Given this list of marker genes ACCS, TM2D2, SEC31A, ZNF609, BAALC-AS1, COPB1, ENSG00000232995, ACIN1, SMURF1, TRIP11, PPP1R37, BRCA2, MRPS11, CNOT8, DDX59, EDEM1, ADIG, ABRAXAS1, LENEP (lens epithelial protein), CDR2-DT, TRABD, DNAJC11, C8G, RANBP9, SRRM5, SCRIB, GLMP, PHF12, SEMA6A, RPS5, IKBIP, LIN37, OTULINL, SLC9A2, RDH13, MIR4727, ALDOC, TFEB, HYI, C4orf46, AVIL, SLC35B2, TRNAU1AP, RNF114, DDX24, PAFAH1B2, PDAP1, RBM34, CRK, FRS3, RGL2, MSMP, NFIC, ASPHD1, DCK, TNFRSF19, ZNF181, GALC, HYI-AS1, ZNF586, EFNA4, MICA, HDDC3, COMT, ZFAND2B, PIGBOS1, METRN, PIGO, RPL36, SLC39A2, NPL, IRF7 (interferon regulatory factor 7), NOL4L, H2AC6, NOL3, PCDH9, VPS11, CUL9, COX7A2, TAOK2, TBC1D10A, SLC39A6, NDUFA6-DT, PRMT5-AS1, H2BC4, ZNF696, PIGV, DEAF1, MBD4, RB1, PARP12, TTC27, TAMM41, NPLOC4, ZNF587, VPS11-DT, OSGEP, ATP2A1, MADD, PRDX5, PPIL2, FPR1, DCAKD, H1-5, ZNF552, XXYLT1, FOXP1, CAPS2, ARPC2, TSFM, TEX38, ATXN7L3, GTPBP4, ZNF875, APEX1, NELFA, ZFTRAF1, TMEM14B-DT, RALGPS2, CPEB3, PYCR1-AS1, BNIP3L, PMF1, SUSD4, VARS2, ATN1, LSM5, RABIF, MRPS18C, IL17RC, GTSE1-DT, TRMT112, LAMTOR3, CNIH4, CISD1 (NCBI Gene Id 55847), RING1, H2AC11, ZNF211, LRIG3, PIGM, RBM28, MRNIP, WDR87, SEPHS1, FBXO4 (F-box protein 4), POP5, PRKACA, RPS6KL1, PHF1, IFT122, KANSL3, THAP3, ZBTB4, RRP7BP, PHLDB1, FAM118B, COX8A, POMGNT2, SAE1, PLS1, TRMT61A, NOLC1, PFDN2, SF3B6, HYPK, KRT15, CENPA, KSR1, WWP1, HCG25, HIVEP1, ANKZF1, FDX2, NDUFAF1 (NCBI Gene Id 51103), SLC25A22, ARFGEF2, MAD1L1, SRRT, FBRS, LNPEP, BMS1P4-AGAP5, FKBP2, IRS3P, GBA1, PSMB4, RTN4RL2, CLP1, RTBDN, CHMP2A, DPM2, ARL2BP, MKKS, SNRNP48, MSTO2P, HAGH, XKR8, TJP3, AIFM1, ALKBH5, HJURP, PSEN1, POM121C, ALKBH3, NECAP1, LBHD1, SEPTIN1, RNASEH2A, SNRNP25, ENTREP3, H3C7, ATG14, MAN1A2, C1QBP, XYLT2, SEPSECS-AS1, SHQ1, COA8, VPS39, ARL6IP6, CYP2D6, ZHX1, AHCTF1, HMBS, RNU6-1, TOR4A, RIN1, FBXL5, STRN4 (NCBI Gene Id 29888), ZNF410, RAB27A, PSMD14, DPH7, AKTIP, CWC25, LSM14B (LSM family member 14B), DCTN3, COQ7-DT, POLD1, MRPL11, LINC01730, ZC3H3, SMC6, ZAR1L, SAMD8, DPY19L2P3, BMS1P4, NME2, PMF1-BGLAP, SMYD3, LTBP4, SNAPC5, TMEM268, TBX6, EFEMP2, RNU6-1251P, SNX19, SIX5, MRPL38, EXT2, ELK1, VPS4A, TES, MRPL21, AKAP8, ATAT1, MLPH, SUMF2, TAF4, SREBF2, DPCD, SUPT20H, QARS1, KMT2D, SUGT1P3 (SUGT1 pseudogene 3), WDR55, CRELD1, CANX, MYL12A, HEXD, MOB4, CTSB, SYT7, IMPDH1, PIGQ, H2BC13, NDUFV3, LRRC46, EML2, WDR73, LINC02939, DAZAP2 (NCBI Gene Id 9802), LRRFIP2, UBR3, ZNF576, GLI1, NECTIN2, SUMF1 (NCBI Gene Id 285362), NAPRT, APAF1, AFF1, ADD1, EVA1B, C8orf33, GTF2A2, INTS12, NOL12, PYGO2, TAF12-DT, PRKCA, TNFRSF10D, ERCC2, KIFBP, CIRBP, PYCARD-AS1, MTHFS, PRKAR2A, MIR9-1HG (NCBI Gene Id 10485), PRR7, SSBP2, MAF1, XRRA1, TALDO1, SUCLA2-AS1, SNTB2, H2BC18, PTOV1-AS1, MTFR2, CSPG5, CHRAC1, MRPL3, SH3GL1, CDC42BPB, SS18L1, LRATD2, TRAPPC14, PPFIA3, ATP2A1-AS1, RRP15, PSMD6, AP2M1, DBNL, GRWD1, DDRGK1, LINC00235, UBE2Z, UBE2C, AP2A2, H2AC8, CD151, NRGN-AS1, CAAP1, GSTZ1, TXNDC16, CWC27, MRPL53, CHD8, PAWR, PPP6C, GMPPB, NSUN7, PLLP, NR2F1-AS1, ACAP2, UCK1, SUZ12P1, TMEM267 (NCBI Gene Id 64417), SCYL3, NDUFC1 (NADH:ubiquinone oxidoreductase subunit C1), JPT2, ERCC5 (NCBI Gene Id 2073), NRGN, KMT5A, RAE1 (NCBI Gene Id 8480), SEMA3A, SPEF1, AMH, B3GNT8, TMEM139-AS1, CDC37L1-DT, ARHGAP44, ZNF8, ZNF587B, ATAD3B, C21orf91 (NCBI Gene Id 89755), UBXN2A, TMEM182 (transmembrane protein 182), LRRC7, RER1, WDHD1, MAPK1IP1L, DGAT1, MEMO1, INO80E (INO80 complex subunit E), ENSG00000260136, SDHAP4, RNA5S12, ACTR6, GTF3C5, KLHDC9, WDR5B-DT, CCAR2, NAGPA, SRM, CREB3L4, AMDHD2, ARHGAP45, DZANK1, INPPL1, NAPA-AS1, INPP5K, ARHGAP4, G2E3, ADNP, TACC1, THOC1, FRMD5, FUZ, CASZ1, NUP210L, ABCA7, DHRS1, CIC, WDR81, BCL9, VDAC2, CHCHD1, SLCO4A1-AS1, UBE3C (ubiquitin protein ligase E3C), PHLDB3, VPS39-DT, KRTCAP3, CASP2, NFATC2IP-AS1, ORAI3, ANKDD1B, ASMTL-AS1, ZNF213, TSR3, TMEM147-AS1, LINC01465, CXorf38, GATC, ANKRD54, ALG5, HIRA, DTD1, ZBTB46-AS2, MMP24OS, MIR150, ARX, ZNF579, DBIL5P, NEU1 (neuraminidase 1), SNHG33, F11R, OGFOD3, MIR141, VIRMA, MTERF1, RCC1, GGN, MYLK3, PTOV1, DDX56, GLCCI1, EIF2D, DBNDD2, C9orf163, COX20, CDYL, MRPL12, RBPJ, TYSND1, TSTD1, MAN2B1, HNRNPL, DDAH2, RARA, PSTPIP1, GLIPR1-AS1, SLC35A5, MED26, LRRC73, CSRNP2, CPSF1, RAI14, AAR2, GRAMD2A, CMTR1, PGD, H2AC14, KAZALD1, PMM1, SEMA3B, SMG1P2, GSTCD (glutathione S-transferase C-terminal domain containing), C6orf136, KCNC3, SIPA1, MNT, SGMS1, LINC02809, LAMTOR1, LRRC1 (NCBI Gene Id 80240), HEXA-AS1, DRG2, GPR137B, RFFL, ACAD10, NUMA1, TOP3B, ZNF606, MRPS26, CDKL3, CCND1, MIR1238, MAML3 (mastermind like transcriptional coactivator 3), REST, CALM3, MIR5695, CTNS, CSE1L-DT, PRAF2, FAAH, SLC4A11, ARID1A, HEXA, TTYH1, SCAMP1, CASP6, LINC01719, NAA10, TNPO2, MYCL, WDR83OS, RABGAP1, GATA5, TMEM242 (transmembrane protein 242), MORC2-AS1, UHMK1, NMT1, MPV17, AARS2, COMMD2, NOP2, SESN2, TXNDC15, IL10RB-DT, SLC35F6, MXRA7, C15orf40, ZNF8-DT, B4GALT7, PCYT2, COQ8A, DBP, GSTO2, UPK3B, KPTN, HMGXB3, YPEL4, GPR35, AGK-DT, ZC3H10, BPNT1, GPC4, UQCC4, ENSG00000269194, EMX1, EIF5, PSTK, MIR4482, RB1-DT, BBS1, GSK3A, MSLNL, PA2G4, GPBAR1, LINC01232, CCDC66, PPP5D1P, KDSR, DHRS13, SLC9A3-AS1, SPACA6, AP1G1 (NCBI Gene Id 164), ACAT2, SSNA1, ATF7IP, TCIRG1 (NCBI Gene Id 8845, T cell immune regulator 1, ATPase H+ transporting V0 subunit a3), RASIP1, MTX1, NRG4, CDC42EP3, ATRIP, MTERF4, SUPT4H1, ALDOA, SDAD1P1, SRCAP, RARS1, NECAB3, MIR4664, SIGIRR, SERINC4, TAF10, PADI1, ZBTB42, PCK2, ARHGDIA, TRAPPC9, NEMP1, SOCS2, MRPL28, MIR4512, CACNG6, FICD (FIC domain protein adenylyltransferase), ELP1, FAM200A, BICD2, PLXNB1, NOM1, SOCS4, ECE1, DNAJA3, GAS2, GPR89B, B3GALT4 (beta-1,3-galactosyltransferase 4), UNC119, ATP5F1E (NCBI Gene Id 514), TUT7, BRAP, FOXA3, CHMP6, ENSG00000261840, PPP4C, PKMYT1, MIR3190 (NCBI Gene Id 100422899), PRPF40A, B4GALT2, DNAAF5, KLHDC2, MTRF1L, CCNDBP1, RECQL4, FAM174C, PALLD, EFNA4-EFNA3, SPCS2, CAPN15, ZNF17, MYL6B-AS1, ZHX1-C8orf76, CLDN7, ZNF839, CITED1, TMEM242-DT, SEPSECS, CENPS, HELQ (helicase, POLQ like), CFAP119, EPN1, SIPA1L3, BMI1, NOP16, TMC4, LINC02934, SNRPC, DGKH, POLR2A, RPL13 (NCBI Gene Id 6137), THBS3, MRPL40, PAQR6, ALG1, NOXO1, ENTPD6, DONSON, CCNF, GPI, FAM133B, SLC4A8-AS1, SLX4IP (NCBI Gene Id 140682), EIPR1, ZNF768, UNC93B1, SYMPK, MINCR, COX18, NAA60, RCL1, SLC1A5, RPS7, ANTKMT (adenine nucleotide translocase lysine methyltransferase), LAMP1, GPAA1, ATP8B3, LARGE2, LAMA5, TIGD6, NFATC4, PNKP, EPRS1, MUC1, ZNF527, FAM53B, NUP85, PKN3, RHOT2, ZGPAT, FAM168B, FGFR4, ZSWIM8, CCNA2, PSMA7, DMPK, MYCBP2, WDR5B, SF3A3, PRPF40B, SNHG30, SELENOO, FBXO16, EBF4, CTXN1, FTSJ3, ESYT1, LTBP3, KCTD15, FAM131A, PTDSS2, TMEM14B, ZNF615, LZTR1, MPI, DPY19L3, COX16, PHPT1, RGS5, ZNF473, RPP30, PRDM15, GDF9, CDK11A, SKIL, GRHL1, USP15, ZNF321P, MIS18A, SYCE2, FAM193B-DT, BAG5, NCOA5, DPY19L4, TENT5A, SEZ6L2, GPX3, EPS15, RNF32, NSFL1C, RNU7-27P, ENSG00000227218, MFSD3, RBM45, C1GALT1, CNIH2, EXOSC6, CDR2, SNORA14B, CENPU, SH3BP2, POLR3F, ZNF513, CD55, PCED1A, GEMIN4, MAT2B, INTS10, BGLAP, FUT10, MYL6, NECAP2, RBM23 (NCBI Gene Id 95712), BSCL2, PFDN5, NFATC3, DPY19L3-DT, ZNF225, RNA5SP115, RIT1, MRPL10, CAPN12, MFSD9, SEC13, NHEJ1, SELENOH, ELMO3, LTO1, ZNF692, SNORC, DMAP1, ATXN10, HOOK2, SGMS1-AS1, RNF40, GARNL3, NR2F2, SART1, VRK3, TIMM13, IARS2, ZRANB2-AS1 (NCBI Gene Id 100132618), UQCC3, RNF32-DT, GOLM2, HTT-AS, SUPV3L1, DHPS, NOTUM, FBXW5 (NCBI Gene Id 54461), RN7SKP175, VCPKMT, IMPA1, NUDT3, RPL39P40, MIR200CHG, GPS2, TMEM144, HUWE1, CTNS-AS1, PPM1M, CRTC2, NOP9 (NCBI Gene Id 161424), MAP4K2, ZRSR2, TRAPPC4, DENND6B, EPCIP-AS1, NEURL2, PAQR4, PEX10, IFTAP, RPUSD4, PDE8A, PYGO2-AS1, PHYHD1, IL11RA, ANAPC5, PRKAR1B, ARFGAP1, RASL11A, H2BC11, BRF2, RHOF, MVP-DT (NCBI Gene Id 123706527), CWF19L1, ZNF544, SLCO4A1, TACO1, SUCLA2, MIR130AHG, LHX3, GTSE1, CDC6, IMMP1L, MRI1, NAB2, SNORD68, AP3B1, EMD, SMARCD2, MLX, TP53BP2, MORN1, LAMB2, DNAJB14, STUB1, KIF16B, WDR83, JMJD4, H2BC5, RAB11A, PPP6R1 (NCBI Gene Id 22870), POLDIP3, TMEM168 (NCBI Gene Id 64418), SMG1P3, EFCAB2, DDIT3, SAP18, ADAM9 (NCBI Gene Id 8754), ACOX3, TAFA2, AIRIM, PNMA1, ATG9A, ELK4, MRPL44, USP19, GMEB2, POLR3K, MFAP3L, SLC25A15, TFAM, MAMSTR, IGHMBP2, POMZP3, ZKSCAN3, FARP2, TTC33, PIPOX, INTS4, AP4E1, SUMO2, MGAT1, CORO1B, BCRP8, MPHOSPH8, TULP4 (TUB like protein 4), FKRP, ZNF213-AS1, TPRN, ZNF606-AS1, PLEKHA8, UNC50, RRP7A, AP3S2, ADCY9, TEX22, NKAP, MTSS2, THOC1-DT, HSPA6, SLC25A25-AS1, RPTOR, WDR4, ZNRF2P2, SRSF6, ATF7-NPFF, LSR, TM9SF2, ZNF607, LANCL2, ZNF8-ERVK3-1, NEIL1, TMEM179B, MXD1, ELP2, HSD11B1L, TMEM147 (transmembrane protein 147), MIRLET7I, OGFOD2, WWOX, GEN1, MAP3K11, ZFAS1 (NCBI Gene Id 441951), IZUMO1, STEEP1, ZNF764, ZDHHC2, SHPK, ZNF510, FEM1A, LINC00630, TMEM191C, ANAPC2, NDUFA4, COA5, USP3, ENSG00000271551, CYC1, CENPS-CORT, SGSM3, TSEN54, ETFDH, SEC1P, TRIM47, POLG2, DAGLA, ZNF3, PIP4K2B, GCLC, CLUAP1, IRGQ, PSMD14-DT, TAF2, MFSD10, IL10RB, BPTF, PGAM2, PPP1R13L, ARFRP1, SPAG4, ABITRAM, CRAMP1, SLC12A6 (solute carrier family 12 member 6), PIK3R2, UNC45A, LARS2, C11orf71, ATF3, GNPTG, ATPAF1, ZSCAN16, IKBKE, MRPS27, DMAC2, PAXBP1, RPL36AL, RNASEK-C17orf49, H3-3B, GLUD1P3, ZMAT2, DAB2IP, IBA57-DT, AMN, MRPL46, TSPAN10, CYBA, AGK, VPS50, NUF2, UBL4A, ACADVL, COQ7, SH3D21, EXOSC8, NADSYN1, TOMM20, KDM1A, PSMC5, CAPNS1, TP53TG5, SIN3A, TTLL3, ZSCAN16-AS1, LRRC14, SH3BGRL2, RRP36, TRMT61A-DT, ACOX2, TRIM65, LIF, CTNNAL1, SNRPE, LINC01775, POLR2J4, FOXM1, ZC3H4, SNX16, PRKAR2A-AS1, RREB1, SKP1, SNX3, BRD3OS, PLK1, ASB3, SLBP, MXI1, USF1, PLA2G10DP, DMKN, PRR7-AS1, CHAC2, MIR200C, OSGIN1, C8orf76, ANKRD13D, ADAT1, SLC50A1, CDK6, IRF9, TSN, RPS6, FAM193B, TRIAP1 (NCBI Gene Id 51499), APBB2, PACS2, MVP, MRPS31P5, GDI1, CDC37L1, CASKIN2, TM2D3, NAP1L1, UBTF, SLC35E3, SPRED2, ZBTB45, SUSD2, MED29, TRIP6, CLN3, HSD17B8, ZNF77, CYTH2, VPS16, SNAP47, CORO2A, SMIM26, LUC7L2, NR4A1, CARS2, PIGB, CDKN2AIPNL, TAF12, DERA, FAM50A, TMEM201, CALR (calreticulin), RNASEK, RPS29, NREP, ZNF814, RBM42, POLR2C, ZNF462, ZNF623, MYG1, ATMIN, LINC02453, GZMM, FAM149B1, RBM15B (RNA binding motif protein 15B), SMTN (NCBI Gene Id 6525), IQANK1, E2F6, ELL3, SLC35B1, NHSL3, TXN2, CLASP2, MARVELD2, COG7, EEF1AKMT1, DHCR7, ARRDC1-AS1, PLAC9, EPHX1 (NCBI Gene Id 2052), RAP2B, UBC, KANSL1L, IBA57 (iron-sulfur cluster assembly factor IBA57), DNAH2 (NCBI Gene Id 57637), SREK1IP1, GMCL1, METTL15, ZNF653, PAM, ASB16, HNRNPAB, EIF3G, RASGEF1B, RALGDS, ABHD18, CTSA, PLEKHG4, VEZF1 (vascular endothelial zinc finger 1), PGBD2, PCGF5, MAZ, PLCH1 (NCBI Gene Id 23007), CD9, ATXN2L, ZBTB11, MICOS13, ABCB9, ZFP90, METTL2B, CENPN-AS1, MLLT3, DNMT3A, RNU5A-1, GLT8D1, SMG8, EDN1, MXD3, HMGB3P22, DDX55, SLC4A8, GATB, KRBA2, CLK3, NPAS3, GNAI2, WDR70, RAP2A, CCNC, EHMT1, SHARPIN, PPP1R15B, GTF2H2C, VIRMA-DT, MDFI, MTFR1L, PAIP1, PUSL1, FBXW9, INO80C, NOP14-AS1, ACTR3, STX6, SLC35A3, HAX1, ZNRF3-AS1, KCTD5, ABHD1, PTEN, FAHD1, SYTL1, DHRS11, LRR1 (leucine rich repeat protein 1, NCBI Gene Id 122769), SPRED3, SAC3D1 (NCBI Gene Id 29901), POMT2, HMCES, SEC24C, GPR137C, MIR3195, FZD6, ARID1B, CDYL-AS1, here is a description of the gene set: species: Homo sapiens Human Gene Set: FXR1_TARGET_GENES Genes containing one or more binding sites for (FXR1) in their promoter regions (TSS -1000,+100 bp) as identified by GTRD version 20.06 ChIP-seq harmonization. from publication Yevshin I, Sharipov R, Kolmykov S, Kondrakhin Y, Kolpakov F (PMID 30445619)